The following is a description of a gene set: Genes down-regulated in comparison of control dendritic cells (DC) at 6 h versus those stimulated with Pam3Csk4 (TLR1/2 agonist) at 6 h. Human Gene Set: GSE17721_CTRL_VS_PAM3CSK4_6H_BMDC_DN from publication Amit I, Garber M, Chevrier N, Leite AP, Donner Y, Eisenhaure T, Guttman M, Grenier JK, Li W, Zuk O, Schubert LA, Birditt B, Shay T, Goren A, Zhang X, Smith Z, Deering R, McDonald RC, Cabili M, Bernstein BE, Rinn JL, Meissner A, Root DE, Hacohen N, Regev A (PMID 19729616) studied in species Homo sapiens mouse primary BMDCs were stimulated with tlr ligands and gene expression changes were profiled on Affymetrix arrays, and this is the list of marker genes: FKBP1A, PTPN23, MDFIC, RPS6KA2, WASHC4, PSMA6, CS, ELL2, FZD3, UBE2M, FLNB, GNPNAT1, PRSS42P, N4BP1, JAK2, MAGED2, KCTD11, IPO4 (importin 4), LMCD1, PAFAH1B2, DCX (doublecortin), SERPINB2, KRTAP13-1, EHD3, FOXD1, FURIN, MMP12, EMD, PA2G4, AP1AR, OPN3, EML6, LAMB1, SRXN1, RIPK2, PABPN1, PDZK1IP1, BAG5, IFNA1 (interferon alpha 1), LRRC59, TNFAIP8, TBX2, HMOX1, PSMB7, SCAMP1, PIK3CG, ANXA7, SYNE2, PALLD, GLIS1, ATL3, PLAGL2, RIOK3, MAP3K8, ELOC, CCT6A, EDEM1, MOB4, NEAT1, IRX3, SLC44A1, NOTCH1, TPH1, LTV1, CES4A (carboxylesterase 4A), KATNBL1, LPP, CCNL1, PPP2R2D, BLOC1S4, THOC3, HARS1, PACSIN3, TRA2B, PITPNB, TOMM22, IL11, PGF, ASNS, ABCE1, SEC61G, AK2, CCN3, APBB2, SPRTN, NOLC1, TMEM243, WASHC2A, STEAP1 (STEAP family member 1), NIBAN1, SRP54, AMBN, DHPS, C1orf52, KIN, KCNMB4, MMP14, KANSL1L, AGO2, CCDC71L, RAB32 (NCBI Gene Id 10981), CYP51A1, NDST4, COPS5, ARTN, RANBP2, GBP4, CDKN1A, CDV3, ZDHHC6, MMP2, ZC3H11A, MRPL20, PTGES (NCBI Gene Id 9536), ZNRF1, POP4, GAL3ST1 (NCBI Gene Id 9514), PTPN11, CPD, PWP2, EEF1E1, BPIFA2, NUDC, MAPK6, CD38, MTMR7, DUSP16, HSPB8 (heat shock protein family B (small) member 8), TMEM183A, IL36RN, HCAR2, CTSK, ETV1, TANC1, SCAF8, APBB1IP, METTL3, SLC31A1, WSB2, IER3, SAMSN1, WDFY3, AHR, ENPP3, BCL2L1, SQOR (sulfide quinone oxidoreductase), MSN, CSPG4, GEMIN6, EIF2S2, GTF2B, RBM19, ABI1, UBE2N, DKK4, CLN5 (NCBI Gene Id 1203), ANXA5, MECP2, ZFR, HNRNPH3, FAM222B, SLC6A13, GRB2, DACH1, ESD (NCBI Gene Id 2098), NIP7 (NCBI Gene Id 51388), UBE2J2, NUP58, RPL3L, FSCN1, ZEB1, ZNF436, SRSF7, QPCT, HNRNPD, SLC10A1, LARP4B, PRKN, CHCHD4, ORM1, PRKRIP1, SPINK1, G3BP1, FRMD6, KRTAP4-11, PRPF40A, CPEB1, PTPN1, KRT33B, NTSR2, ACTN1, RND3, ELAC1, RAB10, PPP1R14D, NSMF (NMDA receptor synaptonuclear signaling and neuronal migration factor), GK, LYAR, ATP1A1, UCHL5